The following is a description of a gene set: studied in species Homo sapiens Human Gene Set: HP_ABNORMAL_FOREARM_MORPHOLOGY An abnormality of the lower arm. Abnormal forearm morphology, and this is the list of marker genes: IFIH1, COL9A1, CILK1, KIF22, ELN, NIPBL, COLEC10, RFC2, JAG1, MMP13, BMP1, TRPV4, FGF10, CLIP2, XYLT1, SKI (NCBI Gene Id 6497), COL1A1, B4GALT7, RAI1, TGFB1, RIT1, TRIO (trio Rho guanine nucleotide exchange factor), MAP2K2, NRAS, SOS2, FANCC, ALG12, COL27A1, SLC26A2, LMX1B, MAD2L2, SLX4, SF3B4, MAP2K1, COL10A1, FANCL, EXT1, DYNC2H1, SAMD9, PIGT, RBM10 (RNA binding motif protein 10), PRKG2, DNAJC30, RECQL4, FGFR3, MACROH2A1 (macroH2A.1 histone), TMEM270, COL5A2, PRKAR1A, FGFR2, COL11A1, SHOX, GTF2IRD1, PLXND1, RAD51, COL2A1, BGN, KAT6B, REV3L, BRCA2, FGF9, EIF4H (eukaryotic translation initiation factor 4H), DONSON, SMC3, TWIST1, BUD23, FLNA, VPS35L, SALL4, SETBP1, CYP26B1, CBL, ESCO2, TNNT3, RAD21, COL5A1, LIMK1, GLI3, APC, FANCG, CHD7, PALB2, TNNI2, VPS37D, BRAF, CCDC8, HDAC8, CDC45, ASXL1, CHST3, RIPK4, RAB3GAP2, HOXD13, RNU4ATAC, NSD2, SOS1, COMP, GNPNAT1, CHN1, AFF4, GDF5, MAGEL2, MLXIPL, TAPT1, CHSY1, CPLX1, SPRED2, ARID1B, BCOR, BMPR1B (bone morphogenetic protein receptor type 1B), B2M, AEBP1, ATR, CSGALNACT1, METTL27, TPM2, MAF, CHRNG, RRAS, OBSL1, FGFR1, SHH, CLCN3, ERCC4 (ERCC excision repair 4, endonuclease catalytic subunit), RFWD3, B3GAT3, CCN2, COL9A3, ZIC3, SLC39A13, MAFB, SOX9, COL7A1 (NCBI Gene Id 1294), NOG (noggin), L1CAM (NCBI Gene Id 4268), PTDSS1, MYH3, MMP9, LAMA5, BHLHA9, MAP3K7, MRAS, RASA2, FGFRL1, IFT81, GSC, IFT43, GTF2IRD2, TBL2, LZTR1, NDN, MASP1, DHCR7, FANCA, FKBP10, SMC1A, CD96, WNT5A, PTPN11, PDE4D, ROR2, RBM8A, ERCC1, FANCI, RPL26, LBR, LETM1, AGA, RAD51C, XRCC2, CANT1, LRP4, BRCA1, CUL7, B3GALT6, LMBR1, SNRPN, NALCN (sodium leak channel, non-selective), PCNT, EP300 (NCBI Gene Id 2033), GPC6, NCF1, TBX15, FANCF, SCARF2, TBX5, BAZ1B, NPR2, CREBBP, PIEZO2, FLNB, SMAD6, IHH, RRAS2, RPS19 (NCBI Gene Id 8378), FANCB, DHODH, GTF2I, COL9A2, TRIP11, BRIP1, FZD2, EXOC6B, P3H1, POR, BRD4, ERI1, EXTL3, KRAS, HOXA11, NOTCH2, UBE2T, IFITM5, FANCD2, BICRA, FKBP6, STX1A, EXT2, TBX3, AFF3, CTBP1, WNT7A, FANCM, TNFRSF11A (TNF receptor superfamily member 11a), ANAPC1, FGF23, DVL1, CCNQ, PITX1, TBX22, COLEC11, FANCE, MECOM, SRCAP, TMEM67, RAF1, TAF6, EIF4A3